The following is a description of a gene set: studied in species Homo sapiens Human Gene Set: MIR6811_5P Genes predicted to be targets of miRBase v22 microRNA hsa-miR-6811-5p in miRDB v6.0 with MirTarget v4 prediction scores > 80 (high confidence targets). from publication Chen Y, Wang X (PMID 31504780), and this is the list of marker genes: RCOR1, DICER1, UNC5C, RNF39, HECW2, MED13, ZNF117, MMP16, TMEM98, EXOC6B, SORBS2, MAP6, SCNM1, SOST, ITGB7, ENC1, MAF, FBXW7, FLVCR2, ACER3 (NCBI Gene Id 55331), BCCIP, SOAT2, FCER1G, TET1, SFMBT1, MAPK8IP2, ZNF280B, DEPDC1B, KRT20, SNX18, RAB33A, PDCD6IP, KRT76, CCND2, BNC2, VAMP3, TOGARAM1, PRRT2, CCDC149, FBXO17, CMTM4, ZNF254, ERLIN1, ABLIM2, TRIM74, VIP, IFNG, CACNA1E, TDRP, ITGAL, EXO1, TCL1A, TNRC6B, TRIM73, ZNF273, ZNF384, TWIST1, AGFG1, POM121, CYP4A22, MKNK1, KCNA2, KLF3, RBPJ, DLST, PSME4, LRP12, MTREX, HECTD1, ANKRD29, SLC25A20, KIF3B, LRATD1